The following is a description of a gene set: Any process that activates or increases the frequency, rate, or extent of integrin activation. Human Gene Set: GOBP_POSITIVE_REGULATION_OF_INTEGRIN_ACTIVATION species: Homo sapiens, and this is the list of marker genes: FERMT2, CDH17 (cadherin 17), CXCL13, RAP1B, P2RY12, RASIP1, PIEZO1, SRC, PLEK, SKAP1, FERMT1